Given this list of marker genes LRRTM2, ABI3, CRIPT, LRFN4, IL1RAP, PTPRS, CBLN1, LRRC4B, PTPRD, GRID2, LRFN1, LATS1, FGFR1 (fibroblast growth factor receptor 1), PRICKLE1 (NCBI Gene Id 144165), PTK2B, CASKIN1, here is a description of the gene set: Human Gene Set: GOBP_REGULATION_OF_POSTSYNAPTIC_DENSITY_ASSEMBLY species: Homo sapiens Any process that modulates the frequency, rate or extent of postsynaptic density assembly, the aggregation, arrangement and bonding together of a set of components to form a postsynaptic density.